The following is a description of a gene set: Underdevelopment of the malar prominence of the jugal bone (zygomatic bone in mammals), appreciated in profile, frontal view, and/or by palpation. Human Gene Set: HP_MALAR_FLATTENING Malar flattening studied in species Homo sapiens, and this is the list of marker genes: RNU4ATAC, COL9A3, UBE2A, POLR1B, AMMECR1, LMNA, DNMT3B, FGFR1, FGFR2, OBSL1, POU1F1, YY1, RAB3GAP1, SATB2, PQBP1, AGL, CCBE1, BMP4, GP1BB, NOTCH3, MED12, JMJD1C, SETBP1, KCNE5, GRIA3, RAB23, DDR2, TONSL, TBL1XR1, SCARF2, MAN1B1 (mannosidase alpha class 1B member 1), APC, BBS7, PEX7, PIGT, KCNJ2, FLNB, POLR1D, MAF, ACSL4, SLC6A8, ARVCF, HNRNPH1, WNT5A, MAPK1, PYCR1, LARP7, POR, ADAMTSL4, TBX22 (T-box transcription factor 22), SHH, ESCO2, SOST, CNOT3, POLR3A, MGP, IPO8, PTH1R, RAB3GAP2, PIGU, CRKL, ASPH, FOXC1, UFD1, TWIST1, SERPINH1, SF3B4, SMAD2, PEX12, TBX4, HBA2, COL2A1, CRELD1, NGF, POMGNT1, FGFR3, DHODH, POLR1C, GORAB, LRP4, PIK3R1, COMT, BCR, EFTUD2, PAX3, PDZD8 (PDZ domain containing 8), NDP, HDAC4, HERC1, PRMT7, SNRPB, COL11A1, HS6ST2, SLC26A2, MYH3 (myosin heavy chain 3), FAT4, COL11A2, PEX1, SF3B2, RBM8A, TMEM237 (NCBI Gene Id 65062), RFX7, ARID1B, TFAP2A, CDH11, MLXIPL, POLE, POGZ, RSPRY1, STAG2, GPC6, LIFR, ATP6V0A2, SEC23A, CANT1, EHMT1, TMEM165, GLI2 (NCBI Gene Id 50806), HBA1, COL5A1, PDE4D, TGFB3, B3GALT6, DLG3, TFAP2B (NCBI Gene Id 7021), NEK1, BGN, FAM20C, BUB1B, KIF7, CDK10, TGDS, SHANK3, NPR3, MBD5 (methyl-CpG binding domain protein 5), NOTCH2, AIFM1, ATP6V1E1, RHOA (NCBI Gene Id 387), ASXL3, RAI1, SETD2, TAT, ZNHIT3, ZFX, SLC2A10, FZD2, COL1A1, RREB1, GJA8, FLNA, CHD7, COL9A2, FAM50A, LRP2, DCHS1, EBP, TBX1, NF1, MAN2B1, PSMC3, PIGA, LRPPRC, PCGF2, RDH11, NECTIN1, LTBP4, TGFB2, ACAN, RLIM, BLM, SLC35D1, ATP6V1A, FOXP1, PYCR2, RNU12 (NCBI Gene Id 574043), ATRX, RPS26, CUL7, KIF22, TFE3, DVL1 (NCBI Gene Id 348497), SEC24C, NTRK1, PLOD3, TGFBR1, PIGV, GJA5, HIRA, HSPG2 (NCBI Gene Id 7796), COL9A1, KCNH1, BMP2, TGFBR2, RUNX2, FBN1, ERF, NSDHL (NAD(P) dependent steroid dehydrogenase-like), SMAD3, SIX3 (SIX homeobox 3), NONO, INPPL1, ELN, COG4, TCOF1, MECP2, SMAD4, TP63, GSC, ZBTB20, CHD6, ROR2